The following is a description of a gene set: Mouse Gene Set: WP_SIGNAL_TRANSDUCTION_OF_S1P_RECEPTOR Signal transduction of S1P receptor studied in species Mus musculus, and this is the list of marker genes: Gnai1, Smpd2, S1pr1 (NCBI Gene Id 99736), S1pr2, Racgap1, Mapk6, Akt2, Sphk2, Akt3, Pik3c2g, Mapk12, Gnai2, Mapk1 (mitogen-activated protein kinase 1), Mapk7, Asah2, Gnai3, S1pr3 (NCBI Gene Id 13610), Akt1, S1pr5, Mapk3, Sphk1, Plcb3